The following is a description of a gene set: species: Homo sapiens Human Gene Set: GOBP_NEURAL_PRECURSOR_CELL_PROLIFERATION The multiplication or reproduction of neural precursor cells, resulting in the expansion of a cell population. A neural precursor cell is either a nervous system stem cell or a nervous system progenitor cell., and this is the list of marker genes: KIF14, TEAD3, TRIM3, KIFAP3, GBX2, HDAC3, VEGFA, DCT, KCNA1 (potassium voltage-gated channel subfamily A member 1), LYN, KCTD13, KDM1A, SHH, DRD2, SMO, MELK, PTN, ZEB2, SIX3, LHX2, EMX1, FGF13, FOXO3, TP53, VEGFC, FGFR1, HHIP, HMGA2, RYK, CDH2, DISP3, AKNA, RARB, NUMBL, SHCBP1, EML1, PTBP2, EMX2, SOX10, CEND1, NF1, SBNO1, SLC16A2, TARBP2 (TARBP2 subunit of RISC loading complex), FZD6, PLXNB2, TOX, CTNNB1 (NCBI Gene Id 1499), PDE9A, SMARCD3, KCTD11, SLC6A4, KDM2B, IFT20, ZNF503 (zinc finger protein 503), NR2E1, GATA2, SPINT1, SIRT2, DAGLA, FZD3, DIXDC1, FLNA, PCM1, ILK, MDK, LIMS2, DMRTA2, RPGRIP1, LEF1, HOOK3, FGF8, PROX1, IGF2BP1, ITGB1, TRNP1, WNT1, ZNF335, NFIA, FRS2, ORC3, RERE, ASPM, NF2, CX3CR1, HEATR1, POU3F3, SHOC2, ATF5 (NCBI Gene Id 22809), FGF2, RORA, RRM1, FOXO1, PSMG1, ARTN, RASSF10, PAX6 (paired box 6), HIF1A, BBS1, CTNNA1, ACSL6, GPR37L1, ADGRG1, LHX5, SOX5 (NCBI Gene Id 6660), ASCL1, LRRK2, TGFB1, FGFR2, IGF1, NDUFS2, VAX1, NUMB, NFIB, PTPRZ1, LRP2 (NCBI Gene Id 4036), LNX2, CDON, DOCK7, TMEM14B, DLL4, EPHB1, NTRK3, MIR137, SLC39A5, CEP120, WNT7A, ID4, RHOA, PITX3, DBX2 (developing brain homeobox 2), WNT3A, WNT2, NAP1L1, ARHGEF2 (Rho/Rac guanine nucleotide exchange factor 2), WNT5A, FOXG1, POU3F2, GLI3, NDE1, WDR47, BTG2, TRIM71, FZD9, ID2, TAFA1, NOTCH1 (notch receptor 1), DAGLB, NBN, OTP, GNAI2, WDR62, SPINT2, MIOS, APPL2, DBN1, NES, INSM1, RAB10, PAFAH1B1, RACGAP1, EGF, ELL3, NEUROD4, SKOR2, CX3CL1, VSX2, DISC1, ARX